Given this list of marker genes Uba52rt, Cyld, Ubc, Optn, Ikbkg, Bag4, Usp4, Ikbke, Ubb, Traf2, Adam17, Tnfaip3, Smpd3, Clip3, Otud7b, Rnf31, Ube2d1, Birc3, Mib2 (NCBI Gene Id 76580), Tradd, Smpd2, Xiap, Chuk, Tnfrsf1a, Ube2d3, Cflar, Nsmaf, Otud1, Fadd, Tnf, Rack1, Sppl2a, Ikbkb, Ube2l3, Stub1, Usp2, Rps27a, Tab3, Mapkapk2, Tab1, Traf1, Ulk1 (unc-51 like kinase 1, NCBI Gene Id 22241), Map3k7, Uba52, Usp21, Ube2d2a, Tbk1, Tax1bp1, Tab2, Rbck1, Sppl2b, Ripk1, Madd, Birc2, Casp8, Spata2, here is a description of the gene set: species: Mus musculus TNF signaling Mouse Gene Set: REACTOME_TNF_SIGNALING